Given this list of marker genes SIX6, PSMD12, ARL1, LUM, SLC38A6, ZNF140, ZFHX4, DOCK7, APOBEC3G, CMTR2, GPC6, TTC9, SIX3, RARB, NR2E1, ADGRV1, MSR1, TRUB1, MICB, SBNO1 (strawberry notch homolog 1), LHX2, CASP7, LY96, SGMS2, TIFA, C14orf39, SIX1, here is a description of the gene set: Human Gene Set: SHARMA_PILOCYTIC_ASTROCYTOMA_LOCATION_UP Pilocytic astrocytomas (PAs) are the most common glioma in children. Whereas many PAs are slow-growing or clinically indolent, others exhibit more aggressive features with tumor recurrence and death. To identify genetic signatures that might predict PA clinical behavior, we did gene expression profiling on 41 primary PAs arising sporadically and in patients with neurofibromatosis type 1 (NF1). Whereas no expression signature was found that could discriminate clinically aggressive or recurrent tumors from more indolent cases, PAs arising in patients with NF1 did exhibit a unique gene expression pattern. In addition, we identified a gene expression signature that stratified PAs by location (supratentorial versus infratentorial). Lastly, we also identified a gene expression pattern common to PAs and normal mouse astrocytes and neural stem cells from these distinct brain regions as well as a gene expression pattern shared between PAs and another human glial tumor (ependymoma) arising supratentorially compared with those originating in the posterior fossa. These results suggest that glial tumors share an intrinsic, lineage-specific molecular signature that reflects the brain region in which their nonmalignant predecessors originated. species: Homo sapiens from publication Sharma MK, Mansur DB, Reifenberger G, Perry A, Leonard JR, Aldape KD, Albin MG, Emnett RJ, Loeser S, Watson MA, Nagarajan R, Gutmann DH (PMID 17283119) Genes up-regulated in pilocytic astrocytoma (PA) from supratentorial regions compared to the infratentorial PA tumors.